Given this list of marker genes RNASEH2B, PTPN2, STX11, IFIH1, RNASEH2A, SAMHD1, STAT1, PTPN22, PRF1, ANKRD55, LSM11, SP110 (SP110 nuclear body protein), STXBP2, IL2RA, RNASEH2C, RNU7-1, IL2RB, CD247, UNC13D, TREX1 (three prime repair exonuclease 1), STAT4, PSMB9, ADAR, PSMB8, POLA1, here is a description of the gene set: studied in species Homo sapiens Human Gene Set: HP_ABNORMAL_CIRCULATING_INTERFERON_CONCENTRATION Abnormal circulating interferon concentration The concentration of an interferon is outside the limits of normal.